Given this list of marker genes CTSB, CTSE, CTSH, ADAMTS7, SERPINI2, here is a description of the gene set: Protease genes down-regulated at tumor-bone interface compared to the tumor alone area. species: Homo sapiens Human Gene Set: WILSON_PROTEASES_AT_TUMOR_BONE_INTERFACE_DN from publication Wilson TJ, Nannuru KC, Futakuchi M, Sadanandam A, Singh RK (PMID 18632634) Breast cancer commonly causes osteolytic metastases in bone, a process that is dependent on tumor-stromal interaction. Proteases play an important role in modulating tumor-stromal interactions in a manner that favors tumor establishment and progression. Whereas several studies have examined the role of proteases in modulating the bone microenvironment, little is currently known about their role in tumor-bone interaction during osteolytic metastasis. In cancer-induced osteolytic lesions, cleavage of receptor activator of nuclear factor-kappaB ligand (RANKL) to a soluble version (sRANKL) is critical for widespread osteoclast activation. Using a mouse model that mimics osteolytic changes associated with breast cancer-induced bone metastases, we identified cathepsin G, cathepsin K, matrix metalloproteinase (MMP)-9, and MMP13 to be proteases that are up-regulated at the tumor-bone interface using comparative cDNA microarray analysis and quantitative reverse transcription-PCR. Moreover, we showed that cathepsin G is capable of shedding the extracellular domain of RANKL, generating active sRANKL that is capable of inducing differentiation and activation of osteoclast precursors. The major source of cathepsin G at the tumor-bone interface seems to be osteoclasts that up-regulate production of cathepsin G via interaction with tumor cells. Furthermore, we showed that in vitro osteoclastogenesis is reduced by inhibition of cathepsin G in a coculture model and that in vivo inhibition of cathepsin G reduces mammary tumor-induced osteolysis. Together, our data indicate that cathepsin G activity at the tumor-bone interface plays an important role in mammary tumor-induced osteolysis and suggest that cathepsin G is a potentially novel therapeutic target in the treatment of breast cancer bone metastasis.